Given this list of marker genes HYKK, DLD, PHYKPL (NCBI Gene Id 85007), PIPOX, DLST, CRYM, GCDH, SLC25A21, ALDH7A1, AADAT, AASS, DHTKD1, here is a description of the gene set: species: Homo sapiens Human Gene Set: REACTOME_LYSINE_CATABOLISM Lysine catabolism